Given this list of marker genes UMPS, ZDHHC6 (NCBI Gene Id 64429), ZNRD2, WASHC2A, SIRPA, ABL1, PHTF2, CDKN2B, RTL8C, NOP2, SNX15, ZNF808, LIPT2, TPRG1L, BANF1, MEA1, NDFIP1, DARS1 (NCBI Gene Id 1615), S100A1, NUP85, NAA38, COMMD4, LSS, ACTR1A, CTDSP1, HEATR6, BTF3L4 (NCBI Gene Id 91408), RMND5B, NFYC (nuclear transcription factor Y subunit gamma), BPNT1, FAM174A, MRPS2, OLFM3, KLF5, PHYKPL, EIF3L, NUDCD1, EML3, KLHL36, RPL23, MYO7A, DIABLO, ZDHHC20, NDUFAF4, TTC39C, SNRPD1, RBX1, UBE2A, SYNCRIP, ABCB6, AP1AR, ZNF274, NUDCD2, ATP5MC1, C9orf40, PPP3CC, MBD3, BYSL, MAPK10, KCNA3, CKS2, PRDX5, RABAC1, SIMC1, ATP5MC3, ASPM, GM2A, KLHL21, MUC13, INTS7, KIAA0319L, TRMT2A, ALAD, SMN1, ZFP64, NDUFS8, MAP3K8, DNAJC28, PAPSS1, SMIM30, GTF3A, EIF4H, UBE2M, SMARCC1, PABIR1 (NCBI Gene Id 116224), PRPF19, NDST4, SLC26A4, TTC13 (NCBI Gene Id 79573), TFEC, DDX18, HRAS (NCBI Gene Id 338029), ARL2BP, ATP5F1B, SLC35A4, TAF10, ARHGEF1, CLPB, GALNT1, CRAT, DHX15, RPL37A, NME3, TP53RK, NDEL1, THAP2, AKR1B15, MLLT11, FASTK, JPH1, CLEC6A, NDRG3, FDPS, TRAPPC2B, UTP6, CCDC47, TSR2, GEMIN6, LTV1, KPNA1, STARD7, CPEB2, BLVRA, SNRPB, CYP2S1, ALDH6A1, CDKN2AIPNL, C18orf32, FASN, BAG6, CLUH, SOD2, FKBP15, NPM1, ORMDL2, PSMB7, PREB, ANXA2, DHX40, HGSNAT, IDH3A, LUC7L, GGH, ATP1A1, POLR3K, NCKAP1, CHUK, DUSP6, TMEM60, PLBD1, LPGAT1, P2RY6, SUPT20H, ACVR1B, UTP18, ADAM17, ARPC1A, SLC38A1, RAI14, UQCRC1, PPP2R5D, CHST12 (carbohydrate sulfotransferase 12), MRPS16, XPR1, RPS6, TMEM129, XYLT2, RECQL, COQ3, FTL, DACH1, CEP250, SUPT16H, EIF1AX, MORF4L2, AATF, DPH5, KICS2, HDLBP, EXTL3, SLCO3A1, DNAJC3, STAG1, FAM184B, FOXD2, REX1BD, PDXDC1, SEC11A, NAP1L4, MCAT, RPL9, CDADC1, OSBPL2, CETN3, GRK1, PRKCSH, POLD2, BORCS5, ASCL2, MRPL20, here is a description of the gene set: from publication Amit I, Garber M, Chevrier N, Leite AP, Donner Y, Eisenhaure T, Guttman M, Grenier JK, Li W, Zuk O, Schubert LA, Birditt B, Shay T, Goren A, Zhang X, Smith Z, Deering R, McDonald RC, Cabili M, Bernstein BE, Rinn JL, Meissner A, Root DE, Hacohen N, Regev A (PMID 19729616) Human Gene Set: GSE17721_POLYIC_VS_PAM3CSK4_8H_BMDC_DN Genes down-regulated in comparison of dendritic cells (DC) stimulated with poly(I:C) (TLR3 agonist) at 8 h versus DC cells stimulated with Pam3Csk4 (TLR1/2 agonist) at 8 h. species: Homo sapiens mouse primary BMDCs were stimulated with tlr ligands and gene expression changes were profiled on Affymetrix arrays